Given this list of marker genes Atp7a, Ddn, Neurog1 (NCBI Gene Id 18014), Htr5a, Ncdn, Grik2, Nsmf, Cpe, Amigo1, Glra4 (NCBI Gene Id 237054), Luzp1, Kcne3, Pgr (progesterone receptor), Cdk5r1, Epm2a, Crh, Crmp1, Klhl24, Anxa5 (NCBI Gene Id 97115), Cyp11a1, Cacna1h, Syap1, Naip6, Ercc8, Bglap3, Cacna1e, Synpo, Pi4k2a, Cnga2, Ptpn5, Kcnb2, Slc5a7, Resp18, Ctnnd2, Kcnc2, Npy, Mapk1, Oprm1, Kcna2, Bdnf, Ckap5, Drd2, Bglap2 (bone gamma-carboxyglutamate protein 2), Astn1, Cacna1c, Gnrh1, Drd4, Pcsk1, Cnga3, Ptprs, Kif5a, Nefh, Rufy3, Ccl2, Naip1, Kcnk1, Csf1r, Gap43, Nell2, Tiam2, Rgs8, Map1b, App, Kcnc3, Cdk5, Kndc1, Ttll7 (tubulin tyrosine ligase-like family, member 7), Npff, Clcn2, Gigyf2 (GRB10 interacting GYF protein 2), Map2k1, Ntsr1, Elavl4, Cnr2, Pcsk5, Cacna1a, Adcyap1, Grip1, Hnrnpa2b1, Grik4, Ntsr2, Th, Epha4, Lypd6, Rgs7bp, Mcrs1, Esr2, Smn1, Brd1, Olfm1, Cck, Gria2, Pde11a (phosphodiesterase 11A), Flna, Prph (peripherin), Serpini1, Kcna1, Cib1, Fzd5, Rbfox3, Septin4, Ppp5c, Crhr2, Slc8a3, Hspb1, Cplx2, Pcmt1, Nefm, Got2, Ngfr, Sema4f, Efna2, Ucn, Astn2, Kcnb1, Tmem266, Kcnab1, Ubxn2a, Sirt2, Fyn, Camk2b, C9orf72, Ppp1ca, Pde9a, Naip2, Sorcs2, Pdpk1, Kng1, Rcvrn, Hdac6, Nucb2, Cacna1d, Zpr1, Rtn4rl1, Mapk10, Wdfy3, Ghrh, Ass1, Pals1, Oprk1, Fchsd1, Syt11, Shtn1, Myo1d, Crhbp, Itga1 (integrin alpha 1), Dip2b, Btd, Rtn4r, Ptprn, Ntrk2, Bglap, Glra1, Azin2, Glra3, Mgat5, Kcnh1 (NCBI Gene Id 16510), Chrna10, Septin14, Lrit3, Slc4a10, Hspa8, Map2k4, Slc17a8, Atoh7, Rtn4rl2 (reticulon 4 receptor-like 2), Slc1a1, Rnf112, Cntnap3, Rack1, Grik3, Asl, Slc12a5, Rogdi, Gjc2, Opn4, Ckmt1, Itga8, Cacna1f, Reln, Trpm2, Eno2, G3bp1, Aif1, Pde10a, Top1, Pcsk2, Fus, Ngb, Glul, Nppa, Pnmt (NCBI Gene Id 18948), Adam11, Mapk8, Scn1b, Penk, Neurl1a (NCBI Gene Id 80633), Tmprss11c, Mapk9, Ccr2, Kng2, Dlg2, Dmwd, Kcnd2, Cryab, Fmr1, Hpca, Tmem100, Cplx1, Lrrk2, Ifng, Gria3, Drp2 (NCBI Gene Id 13497), Dbnl, Cpne5, Pam, Slc2a3, Naip5, Endog, Grik5, Cpne6, Dhx36, Ctsl, Arpc2, Esr1, Cnga4, here is a description of the gene set: Mouse Gene Set: GOCC_PERIKARYON studied in species Mus musculus The portion of the cell soma (neuronal cell body) that excludes the nucleus.